The following is a description of a gene set: species: Mus musculus Mouse Gene Set: chr8C2, and this is the list of marker genes: Brme1, Mir709, Mir23a, Rnf150, Gm8167, Gm18212, Mir1199, Lyl1, Clgn, Gm31105, Gm31545, Ndufb7, Scoc, Il15, Prkaca, Nfix, Mir181c, Mri1, Gm4899, Ucp1, Mir181d, Podnl1, Gm38590, Gm15660 (NCBI Gene Id 100416356), Tbc1d9 (NCBI Gene Id 71310), Farsa, Gm4891, Ier2, Gm33242, Rad23a, Rfx1, Tecr, Gm25267, 1700122E12Rik, Nacc1, Mir3074-2, Mir1668, Calr, Gadd45gip1, Gm23626, Gm25138, Elmod2, Gm10645, Adgrl1, Ddx39a, Gm5910, Mir8111, Zswim4, Gab1, Gm7997, Gm18000, Adgre5 (adhesion G protein-coupled receptor E5), Or10k2, D8Ertd738e, Rln3, Gm17169, Gm10644, Misp3, Cc2d1a, Mir24-2, Gm9520 (NCBI Gene Id 671182), Dand5, Gm18001, Gm9655, Samd1, Cacna1a, Gm5354, Zfp330, Nanos3, D830024N08Rik, G430095P16Rik, Trmt1, Gm17999, Inpp4b, Frem3, 1700067K01Rik, Ptger1, Il27ra, Palm3, Mgat4d, Dcaf15, Mir27a, Gipc1, Gm16183, 4930505O20Rik, Asf1b, Pkn1, 4930579O11Rik (RIKEN cDNA 4930579O11 gene), Dnajb1, Smarca5, Gypa, Yju2b, Usp38, Gm17072